The following is a description of a gene set: Human Gene Set: AR_Q2 Genes having at least one occurrence of the motif AGWACATNWTGTTCT in the regions spanning 4 kb centered on their transcription starting sites. This matches the AR transcription factor binding site V$AR_Q2 (v7.4 TRANSFAC). species: Homo sapiens, and this is the list of marker genes: RBMS1, SEMA4C, EIF4ENIF1, OTP, TLE3, NDP, STRIP1, AMMECR1, CYLD, TSHZ3, NCDN, HOXC4 (NCBI Gene Id 50712), AGER, MAP1B, RBM3, SEC16B, BARHL2, PAX3, KLF15, BDNF, TMEM86A, SFXN5, PLEKHA6, SNAP25, WDR47, FIP1L1, ZNF423, RELCH (RAB11 binding and LisH domain, coiled-coil and HEAT repeat containing), GSDMA, MCMBP, ARMC5, HAPLN1, AMY2A, GANC, FGF23, IKZF2, HOXB6, IL16, SREK1, LINC00472, SYNCRIP, ZHX2, SKIL, PPARGC1A, RIMS2, KCNK12 (NCBI Gene Id 56660), PSME2, RERE, KCNA5, RREB1 (ras responsive element binding protein 1), FEZF2, ABCG2, USP54 (ubiquitin specific peptidase 54), MAP4K5, LUC7L3, KCTD15, FOXP2, LRP1, KCNJ1, RARB, ERGIC1, GSX1, HECTD4, YTHDF3, PPP1R2B, CLDN17, PFKFB4, LARP4, TSC22D3, DMD, GSK3B, EIF4EBP1, SDCBP2, CPEB4, C2CD2L, WNT3, CD36, DACH1, GRHL2, ITGA6, TRAF6, ADCYAP1, APPBP2, CDC42EP3, SLC12A8, NFE2, LUC7L, GRWD1, HNRNPUL1, HOXA3, ENKD1, PIEZO2, TFAP2D, KCNK10, SESN3, FOXA1, ECI1, DLX3, MSTN, ETV6, SLC18A1, HIVEP1, ADNP, LINC00114, PHOX2B, RAB11A, VCPIP1, ANKS1A, DAB2, ADAM7, LSM14B, INHBA, NPHP4, FGF14, HOXC6, GJB1, TNS2 (tensin 2), APOLD1, TRIP11, CAPNS2, RWDD1, CA11, PAX9, PPP2R1B, SIX3, WNT9A